The following is a description of a gene set: Human Gene Set: GOBP_REGULATION_OF_MATRIX_METALLOPEPTIDASE_SECRETION studied in species Homo sapiens Any process that modulates the frequency, rate or extent of matrix metallopeptidase secretion., and this is the list of marker genes: MIR199A1, TLR4, RAP1GDS1, BSG, SLC12A2, TLR2, MIR766, IDH2, CD200, MIR19B1, MIR29B1, MIR19A, MIR146A